Given this list of marker genes IFNGR1, FOXP3, ALDOA, TWIST1, HGSNAT, TMEM107, MPEG1, TLR4, CCBE1 (collagen and calcium binding EGF domains 1), HFE, SHARPIN, TRIM28, SPAG1, KMT2D, CASK, SLC7A7, RNASEH2A, EPG5, TNFSF4, AFF4, USP53, ZFYVE19, ANKRD55, DNAL1, RASGRP1, ZBTB16 (zinc finger and BTB domain containing 16), RFXAP, CEP290, POLD3, SDHD, GLRX5, TGFB1, RSPH1, ODAD3, HMGA2, STAT5B, GLB1, PARN, MPIG6B, PRDM16, OCLN, TMEM67, MIF, CSPP1, ZAP70, HCK, SGSH, MYCN, BLK, IFNG, LMO1, DRC1 (dynein regulatory complex subunit 1), PHKG2, PSTPIP1, GBE1, ANK1, ZNF699, RSPH3, FAS, IL2RG, STRA6, CD28, LCAT, NPC2, HRAS, FARSA, POLR3A, TXNDC15, PIK3CG (NCBI Gene Id 5294), PNPLA2, TALDO1, GCLC, PHKA2, FAH, GPC4, PRKAR1A, GBA1, INPP5E, PTH1R, ISG15, BMP2, FGB, KCNH1, JAZF1 (JAZF zinc finger 1), STIM1, AK2 (NCBI Gene Id 83165), CDAN1, OFD1, NCF2, ORAI1, SPTB, GNE, HBA1, CCDC39, SPP1, POLR1B, RIT1, CPOX, CD70, HSPG2, TFAP2A, CD27, DNAAF5, CCDC40, BANK1, TNPO3, WNT3, IL6, ESAM, LZTR1, ALG14, BPGM (NCBI Gene Id 669), GNPTAB, PIK3C2A, ATM, RUNX1, UROS, SKI, CR2, DLK1, MTHFR, MAP2K1 (NCBI Gene Id 5604), TERT, IL12A-AS1, SKIC3 (SKI3 subunit of superkiller complex), PIBF1, DNAI1, DNAH5, NOTCH1, RBCK1, MCIDAS, LPL, PSMB10, CYP27B1, MEG3, IRAK1, TFE3, GATA1, XIAP, RFWD3, GAS2L2, EIF2AK4, NUMA1, PKHD1, NFATC2, TNFSF12, NF1, RRAS2, COG1, TRNT1, RSPRY1, NUAK2, REST, SLC25A13, PTPRC, BRCA1, BCR, TCIRG1, ALG9, KCNN4, OTULIN (NCBI Gene Id 90268), POT1, RASA1, MYO5A, GNS (glucosamine (N-acetyl)-6-sulfatase), NRAS, FUCA1, CTSA, CCR1, IL2RA, DNAAF1, CASP8, RREB1, MALT1, GPR35, FYB1, NLRC4, ARPC1B, JAK1, RORC, ODAD2, PEX13, HABP2, BCL6, SLC19A1, TNFRSF1A, FCGR3B (Fc gamma receptor IIIb), APOE, MMP21, CTNNBL1, LEMD3, SOS2, CDKN2A, LUZP1 (leucine zipper protein 1), DCLRE1C, MS4A1 (NCBI Gene Id 931), RAB23, SP110, CFAP300, CXCR4, CAV1, FRAS1, IFT140, COG6, NFKB1, MECP2 (methyl-CpG binding protein 2), RAC2, PEX2, TPI1, ALAS2, GATA2, INPPL1, FCHO1, CELSR1, COG7, AKR1D1, CDKN1A, B4GALT1, XK, CARD9, ACD, CD55, NODAL, KRAS, ALK, IL7R, GPI, CC2D2A, SPEN, CASZ1, BCL2, NME8, MEGF8, HLA-B, MPV17, BACH2, MCM10, TET2, POLR1D, TBX2, H19, CCND1, PALB2, ERAP1, EP300, NPM1, NEK8, SUMF1, PSMB4, YME1L1, LRBA, HSD3B7, TMEM237, TRAC (T cell receptor alpha constant), PSAP, CYBB, TP53, SF3B1, IL12A, VANGL2, JMJD1C, CFAP74, TNFRSF11A, GUSB, TCF3, SPIN4, FGFR2, LMNA, GABRD, DDRGK1, TNFSF15 (NCBI Gene Id 9966), DLEC1, STX11, ITGAM, UNG, SAMHD1, ITCH, B9D1, RARA, DNAH11, NSMCE3, GSN, BCL10, RSPH9, SPEF2, HPGD, ABCG8, RNF6, DYNC2LI1, DPM1, CTSK, NKX2-6, RASA2, TBK1, G6PD, PPP2R3C, DKC1, KCNAB2, CBL, PIGM, SCYL1, DNAJB13, FREM2, KATNB1, MICU1, USB1, HAVCR2, PTPN2, MOGS, FOXP1, RHD, PEPD, CALR, DZIP1L, OAS1, CFAP45, TYMS, LETM1, TNFRSF13B, ATP8B1, TBXAS1, OTC, SH2D1A, SAMD9 (sterile alpha motif domain containing 9), ZIC3, IL10, ZMYND10, TMEM216, TTC7A (tetratricopeptide repeat domain 7A), TRIP13, SLC30A10, LYST, KIF3B, DNASE1L3, CYP7B1, RRAS, ETS1, MAN2B1 (mannosidase alpha class 2B member 1), FASLG, CCNO, TNFRSF13C, PIK3R1, BTK, APOC2, PI4KA, LTBP4, NHP2, PSMB8, DNAAF11, NME5, AGPAT2, HBG2, GALK1, CFAP221, POU2AF1, SAMD9L, RHAG, TNFRSF4, IL1RN, PIGA, MRAS, SOS1, FOXF1, PSMG2, LPIN2, HLA-DPB1, CLPB, PIEZO1, RERE, NFKBIA, ARPC5, WAS, NOP10, HYLS1, FOXN1, SMAD4, DNAI2, MEN1, ATP6AP1, PLCG1, NABP1, PHYH, GDF1, KLF1, WT1, SLCO2A1, WNT7B, ALMS1 (NCBI Gene Id 7840), HAMP, UBR1, BTD, STAT3, RELN, SLC39A4, INSR, CA2, GLIS3, POU6F2, MCTS1, ITK, IDH1 (NCBI Gene Id 3417), WRAP53 (NCBI Gene Id 55135), ABCD3, RTEL1, PRF1, TCTN1, BSCL2, MECOM, LACC1, MYO5B, NDUFS4, CTC1, GPIHBP1, LYN, ACVR2B, CDKN1B, RTL1, SLC17A5, BAP1, SPIB, DLL4, DEF6, P4HA2, RINT1, ERBB3, GINS1, PML, VPS45, CFAP298, NBEAL2, SEC23B, RARB, LRRC56, SCNN1B, PRKCD, SEC61A1, IL6ST, FGFRL1, COX4I2, GIMAP5, NEU1, CPLX1, ALG1, ALPK1, TPP2, UBE4B, POMP, C4B, DNAAF2, COMT, SH3BP2, CHD7, RAB27A, PTEN, ABCA1, MC1R, CCDC47, CD19 (NCBI Gene Id 930), SOCS1, RNF31, RFX5, MYD88, BTNL2, KIT, LIPA, STEAP3, NSD2, ERCC6, STAT4, AGR2, LAT, IGHG1, TP63, SKIC2, WWOX (WW domain containing oxidoreductase), MPL, FAM111A, VPS13A, MYC, ABCA12, MAGT1 (NCBI Gene Id 84061), SRSF2, AKT1, ERCC8, GAA, RABL3, EPOR, FAT4, PALLD, MMP23B, NHLRC2, PPARG, EXOC2 (exocyst complex component 2), TLR8, SOX18, ARSB, C3, CCDC115, PKLR, NEK10, MEFV, MYRF, FOXE1, IKBKG, TNIP1, SNX14, BLM, TCTN3, F5, UMPS, NAGLU, DNAAF4, CREBBP, RIPK1 (receptor interacting serine/threonine kinase 1), TERC, MVK, CYBA, DNASE2, MINPP1, NFKB2, FIP1L1, IL2RB, HBB, PSMB9, HACE1, SCNN1G, TINF2, TBX1, CASR, FLT4, PRIM1, ASXL1, IGHG2, SNX10, STING1, TNFRSF1B, AGA, ACP5, PTPN11, RNU4ATAC, HMOX1 (heme oxygenase 1), CASP10, ANTXR2, IRF1, MST1, TNFRSF9, ATRX, TTC12, RHCE, SMAD2, VPS11, IKZF3, SPTA1, IRF8, PHEX, FGG, CDKN2B, DCDC2, ABCB4, COG4, HBG1, MPI, PTPN22, ESCO2, HSD17B4, DIS3L2, CD3E, PDPN, G6PC3, CD247, SLC4A1, ATP6V1B2, GP1BB, RNU7-1, TSC1, WDR1, SAA1, TGFBR2, NOD2, CTNS, RMRP, LIG4, POLR1C, EPHB4, NPHP3, HIRA, GEMIN4, PDCD1, MITF, JAK3, SYK, NGLY1, HJV, FOXJ1, DHCR7, VPS33A, TNFAIP3, HEXB, ADAMTS3, TMEM231, IRF2BP2, KPTN (kaptin, actin binding protein), PHKB, NEK9, BCL11A, CTBP1, BRCA2, CFC1, RPSA, RAG2, WIPF1, TCTN2, ODAD4, CD3D, NCF4, COL18A1, UROD, B9D2, RNASEH2C, ATP7B, DHCR24, SEMA4D, CFTR, XRCC4, TCOF1, ABCG5, ADA2, HYDIN, YARS1, SLC29A3, NCKAP1L, UBE2L3, DOCK11, FERMT3, CENPF, PIK3CA (NCBI Gene Id 5290), PIK3CD, MGMT, DNAH9, TCF4, RAF1, SEC24C, PDGFRA, MNS1, HBA2, FMO3, CFAP410, ASAH1, ADAR, IL23R, NLRP1, FCGR2B, TSC2, PAK2, CD40, ZNFX1 (NCBI Gene Id 57169), RPGRIP1L (RPGRIP1 like), ELANE, IL12RB1, CYP2R1, BMP6, SCARB2, CTLA4, IRF4, MMUT, KIAA0319L, TBL1XR1, IGKC, COG5, MCM4, C4A, STAT1, MMEL1, BRAF, ICOS, UBAC2, IRF5, AIRE, CDKN2C, TNFSF11, NLRP3, MAP2K2, BCOR, KCNN3, PHOX2B, ARVCF, TULP3, GALE, PRKCZ, FOCAD, TREX1, COL1A1, THPO, NAE1, SH2B3, FCGR2A, PLEKHM1, MED12, NCF1, PEX7, AICDA (NCBI Gene Id 57379), RBM8A, UFD1, IARS1, PXK, IFT56 (intraflagellar transport 56), DNAAF6, SETBP1, DNAH1, IDH2, IFT172, CD81, CCDC32 (coiled-coil domain containing 32), GP1BA, NLRP12, SMPD1, STK36, SAT1, OSTM1, CDON, TLR7, DNAAF3, EPB42, FGA, SERPINA1, SCNN1A, IFIH1, COX10, PNP, AKT2, LSM11, ZEB2, PEX5, JAK2 (Janus kinase 2), AP3B1, CYBC1, NOTCH2, LBR, RNF168, STXBP2, TERF2IP, PLXND1, GPC3, VPS33B, TRPV6, RPGR, SLC37A4, IDS, CLCN7, RAG1 (recombination activating 1), NDE1, CDC42, BIRC3, STAT2, SLC2A1, RSPH4A, DNASE1, ZBTB7A, LIN28B, ODAD1, IDUA, HK1, CARD11, EWSR1, AP3D1, SPRED2, RNASEH2B, GNB2, HMBS, ADA, ABCB11, GYPC, CDK4, ABL1, KLRC4, DGUOK, KDM6A, RPGRIP1, GPD1, MKS1, HLA-DRB1, NPC1, UNC13D, CDIN1, EPB41, CAVIN1, CD40LG, PDGFB, SOX10, CSF3R (NCBI Gene Id 1441), CLDN1, WDR35, CLXN, here is a description of the gene set: An anomaly of the lymphatic system, a network of lymphatic vessels that carry a clear fluid called lymph unidirectionally towards either the right lymphatic duct or the thoracic duct, which in turn drain into the right and left subclavian veins respectively. Abnormality of the lymphatic system species: Homo sapiens Human Gene Set: HP_ABNORMALITY_OF_THE_LYMPHATIC_SYSTEM